The following is a description of a gene set: NNK to DNA adducts. Pathway ID: N01381. Pathway type: Env factor. Pathway class: nt06250 DNA adduct formation. Human Gene Set: KEGG_MEDICUS_ENV_FACTOR_NNK_TO_DNA_ADDUCTS Pathway Definition from KEGG: NNK -- (AKR1C2,CBR1,HSD11B1) >> (CYP2A6,CYP2A13) -> C19577 -> C19568 -> C20302 == DNA species: Homo sapiens, and this is the list of marker genes: CYP2A13, CBR1, AKR1C2, CYP2A6, HSD11B1